Given this list of marker genes SOX6, ASCL1, OLIG2, NKX2-2, SOX13, here is a description of the gene set: species: Homo sapiens The process in which neuroepithelial cells in the neural tube acquire specialized structural and/or functional features of oligodendrocytes. Oligodendrocytes are non-neuronal cells. The primary function of oligodendrocytes is the myelination of nerve axons in the central nervous system. Differentiation includes the processes involved in commitment of a cell to a specific fate. Human Gene Set: GOBP_SPINAL_CORD_OLIGODENDROCYTE_CELL_DIFFERENTIATION